Given this list of marker genes EVC, NECTIN4, EVC2, WNT10A, NECTIN1, KREMEN1, AXIN2, WDR35, NLRP1, ORAI1, CDH3 (NCBI Gene Id 1001), EDAR, HOXC13, EDARADD, IFT122, MBTPS2, ATP6V1B2, PKP1, GJB6, IFT43, SMARCAD1, IKBKG, NFKBIA, EDA, KANSL1, TP63, here is a description of the gene set: Human Gene Set: HP_ECTODERMAL_DYSPLASIA Ectodermal dysplasia is a group of conditions in which there is abnormal development of the skin, hair, nails, teeth, or sweat glands. species: Homo sapiens Ectodermal dysplasia